Given this list of marker genes Fst, Qsox1, Tgfbr3, Ywhag, Pcp4, Fn1, Acta1, Gja1, Pigr, Dsg2, Alpl, Trp53inp2, Cdkn2b, Hoxa10, G6pd2, Hoxa11os, Hoxa11, Aldh1a2, Gm33887, Aoc1, Col15a1, here is a description of the gene set: Mouse Gene Set: YAO_HOXA10_TARGETS_VIA_PROGESTERONE_DN studied in species Mus musculus from publication Yao MW, Lim H, Schust DJ, Choe SE, Farago A, Ding Y, Michaud S, Church GM, Maas RL (PMID 12554760) Genes down-regulated in the uteri of ovariectomized mice 6 h after progesterone injection: HOXA10 knockout vs wild type animals. Human infertility and recurrent pregnancy loss caused by implantation defects are poorly understood. Hoxa-10-deficient female mice have severe infertility and recurrent pregnancy loss due to defective uterine implantation. Gene expression profiling experiments reveal that Hoxa-10 is an important regulator of two critical events in implantation: stromal cell proliferation and local immunosuppression. At the time of implantation, Hoxa-10 mediates the progesterone-stimulated proliferation of uterine stromal cells. Hoxa-10 mutants express a stromal cell proliferation defect that is accompanied by quantitative or spatial alterations in the expression of two cyclin-dependent kinase inhibitor genes, p57 and p15. Hoxa-10 deficiency also leads to a severe local immunological disturbance, characterized by a polyclonal proliferation of T cells, that occurs in place of the normal progesterone-mediated immunosuppression in the periimplantation uterus.